Given this list of marker genes SYPL2, PWWP4, DNAJC21, TDO2, NHLRC1, PPM1E (protein phosphatase, Mg2+/Mn2+ dependent 1E), TOM1, ZC3H18, KIF24, CCDC183, PLEK2, IGFBP1, MARCHF4, ZNF367, SLC6A20, DCUN1D5, NKX6-2, AFDN, NOL10, GNPNAT1, DNAJC1, MGME1, KDM5B, YEATS2, LIG1, CLSTN1, MBOAT7, PAICS, SLC6A14, PRDX1, KCNMB2, GARIN5A, HDAC6, STMND1, ZNF879, TMEM41B, BOLA3, ABHD4, TIMP2, ADAT1, ITGA2, EIF1AD, FOXRED2, LRMDA, SLC36A1, ADAMTS5 (ADAM metallopeptidase with thrombospondin type 1 motif 5), VWCE, VPS39 (VPS39 subunit of HOPS complex), HUS1, DERL2, CDCA5, NTF3, MTMR7, CYB561, GGH, POLR3K, MTF2, EDN1, HIKESHI, EFNA1, SLC6A3, CNOT11, NEFM, MTRF1L, RFC5, LRP2BP, CDC42EP4, ERBB3, ACCSL, ROBO4, MUTYH, CHRNA5, UGT2B15, CFAP126, TMPRSS4, EPM2A, CLCN2, DGLUCY, CDC25C, APMAP, PRRX1, SOWAHA, FES, QDPR, TEX15, ANXA11, INCENP, RASAL2, NUDT6, FHL5, UBE4A, MATCAP1, PRELID3B, TMEM92, HASPIN (histone H3 associated protein kinase), MRPL39 (mitochondrial ribosomal protein L39), EID2, GSDMA, TENM1, TARBP2, PIGF, SMIM6, COMMD1, GSTM1, SRPRB, ACTRT1, IPO9, GTSE1, GATAD2B, HEY1, PAQR5, GINS4, GAS2L3, DIS3, HIGD1C, NR2F6, LRR1 (leucine rich repeat protein 1), GEN1, ACER3, TRANK1, EME1, MLEC, GCSAM, RIN2, TUBE1, ARRDC5, ZNF786, SPTBN4, DAP3, ARHGAP20, THOC1, PROKR1, RUFY2, CPEB1, TBC1D7, CTNNA1, TMEM79, BTN1A1, CCDC162P, GLS2, FRK, PTPN20, PYROXD1, RSU1, UXS1, WHRN, VASN, RPP25, BTBD10, ADGRF1, KIF1C, ZBTB12, NUDT17, NUDCD2, GPN2, CAD, PDE4DIP, FRA10AC1, KRTDAP, FAM20B, TJP1, CYLC2, SUB1, CYP2F1, EXOSC9, NTN3, CYGB, PURB, PATL2, CPTP, COL5A1, HINT1, PTPRU, ADAMTS3, GLYR1, CATSPER3 (NCBI Gene Id 347732), BRD3, PNLIPRP2, IL3RA, LCN12 (lipocalin 12), APIP, WDSUB1, SCLT1, CKS1B, AFF2, DNASE2B, ORC6, HK2, TSACC, CCBE1, FUT1 (fucosyltransferase 1 (H blood group)), RSPH1, ZBTB8A, GCNT3, SSPN, RHOU, TPX2, SELENOS, SRP72 (signal recognition particle 72), here is a description of the gene set: from publication Edwards JP, Zhang X, Frauwirth KA, Mosser DM (PMID 16905575) Genes up-regulated in activated macrophages: classically (M1) versus alternative (M2). species: Homo sapiens The purpose of this study is to identify novel markers for the type II activated macrophage, which is generated by classical stimulation in the presence if IgG immune complexes. These cells gererally produce high levels of IL-10 and low levels of IL-12, in comparison to classically activated macrophages. We wish to identify gene expression which is enriched in Type II activated macrophages in comparison to classically activated macrophages. Human Gene Set: GSE4811_CLASSSICALY_ACTIVATED_VS_TYPE_2_ACTIVATED_MACROPHAGE_UP